The following is a description of a gene set: Mouse Gene Set: GOMF_ADENYL_NUCLEOTIDE_EXCHANGE_FACTOR_ACTIVITY species: Mus musculus Binds to and stimulates the hydrolysis and exchange of adenyl nucleotides by other proteins., and this is the list of marker genes: Bag3, Bag4, Bag1, Hspbp1, Hyou1, Grpel2, Hspa4l, Bag2, Hspa4, Hsph1, Grpel1, Sil1, Bag5, Pfn1